Given this list of marker genes SP100, HNF1B, LRRN4, EFCAB2, TBL1XR1, ABCA9, NHSL3, TNFSF8 (TNF superfamily member 8), TCF12, EPHA3, RPRD1A, TTR, RCAN2, TACC2, RBPJ, LRP1, PTGIS, MFAP5, KLHL18, ZFHX4, IDI2, PRRX1, RFX3, TBCK, DCDC2, PPFIBP1, FN1, CREB3L3, CACNA1B, MXI1, SATB2, GRIK3, ZMYM1, PLAAT2, MYOZ2, DBT, TENT2, ZFHX3, TRUB2, ISY1, ZC2HC1A, LINGO2, TRABD2A, DNAI4, SORCS1, TMEM154, WDR26, ILDR2, DCTN4 (NCBI Gene Id 51164), TMPO, IL12B, TSHZ1, ROBO2, KMO, TNFSF15, IGF1, CCNYL1, RSRC1, ENSG00000275993, MECP2, SORL1, ZFP90, CBLN2, SYNJ2BP, TRAPPC3, LSMEM1, SIK1, MRS2, XPOT, ABO, MGAM2, PRKCA, PCGF3, ACSL3, KCMF1, KCTD1, RHOH, CCN3, ARFGEF3, A1CF, HOXA4, SLC25A26, here is a description of the gene set: Human Gene Set: MIR4711_3P studied in species Homo sapiens Genes predicted to be targets of miRBase v22 microRNA hsa-miR-4711-3p in miRDB v6.0 with MirTarget v4 prediction scores > 80 (high confidence targets). from publication Chen Y, Wang X (PMID 31504780)